Given this list of marker genes ERCC1, KIAA0319, XBP1, DDRGK1, SHARPIN, RGS8, HSPA5, TRAFD1, KLKB1, MMP14, TRIM11 (NCBI Gene Id 81559), TAF9, TKFC, MIR101-1, HFE, PDCD1, ADRB2, DGKD, TMEM64, IGBP1, EIF3A, MAGI2, TRABD2A, FBP1, TSKU, AKT1S1, HDAC7, DAB1, CLASP2, MPIG6B, SMCHD1, TRIM21, CGAS, MIR20A, PID1, FGG, INPP5A, PPP3CB, PADI2, UBASH3B, LRRC14, CDK3, IFNA2, MIR4286, MIR130A, GGNBP2, ELF1, ARR3, SYNJ2BP, ARG2, TNIP2, PTPN3, MIR130B, SQSTM1 (NCBI Gene Id 94002), EXTL3, SIRPA, CHRD, RHOH, BDKRB2, CUL3, CIT, ARHGAP12, CDK12, MIR31, RNF43, RRN3, MIR26B, FOXO1, ATAD3A, UCHL1, ATM, CCR2, SHH, CYRIB (NCBI Gene Id 51571), IRAK3, RGS13, MIR483, PLK1, ADAMTS12 (ADAM metallopeptidase with thrombospondin type 1 motif 12), CST7, RTCA, HOMER2, EID2, COMMD1, TAX1BP3, USP20, MAD2L2 (NCBI Gene Id 10459), ERCC6 (ERCC excision repair 6, chromatin remodeling factor), NCOA7 (NCBI Gene Id 135112), FEM1A, ARHGAP29, MIR9-1, PKHD1, CCDC22, TAF1, RASGRF1, PPARA, IL1RL1, IRGM, NUDT16L1, TXNDC12, YJU2, GPATCH3, BCL9L, TRAF3IP1, MIR125B1, HTRA1, EZH2, KNG1, MICOS10-NBL1, SAR1B, TBC1D7, DKK1, MCC, MIR323A, MIRLET7G, AZI2, AMBP, PIAS4, SIGIRR, NGFR, FZD9, SEC13, IGFBP6 (NCBI Gene Id 3489), BCL2L12 (NCBI Gene Id 92647), LMNA, NCOR2, GPRC5A, NPY5R, MIR99A, MIR1224, MLLT3, RTEL1, SMAD6, PRKCZ, CREBRF, TP53, HGF, PELI3, NPC1, TNFRSF14, FRMD8, ACOD1, RGS21, PYCARD, MAPK14, RGS17, ATXN1, FURIN, PIK3CB, VSIG4, SH3RF1, METRNL, FCGR2B, PAK1IP1, ADAM17, SERPINB2, RGS3, BRD4, MEAK7 (MTOR associated protein, eak-7 homolog), MIR1298, PSMA1, RASA4 (RAS p21 protein activator 4), YWHAE, FHL2, OFD1, HDAC3, CSNK1E, CASTOR1, USP18, MIR181C, MEN1, MAGEA1, ENG, ELL3, DLX2, PCGF2, MIR708, WTIP, SENP3, WNK1 (NCBI Gene Id 9872), CDK5RAP3, MIR326, KLHL31, TARBP2, NECAB2, TMEM127, ARID4A, EPHA4, PREX2, BAX, GRK3, MIR92B, CDH2, CSNK1A1L, EGR1, MTNR1B, GFRAL, TLR6, FAP, TLE2, PDGFRA, ITGAV, HLX, ADORA2A, RTN4R, GPR18 (NCBI Gene Id 2841), STAT1, CYP26B1, MIR19B1, HLA-B, MIR361, ZBTB7B, NME5, NDUFC2, ADTRP, SMURF2, ZDHHC12, CD22, RORA, APCS, IL2RA (interleukin 2 receptor subunit alpha), HHEX, SLAMF8, MIR210, BTRC, MAPKBP1, SERPINF2, MIR16-1, FGF10, SFRP2, INS, OLFM4 (NCBI Gene Id 10562), TEK, MIR520C, APCDD1L, SPRED2, MARCHF7, PMEPA1, DYRK3, PHF14, SKA3, AIF1 (allograft inflammatory factor 1), GIT1, DLG1, CRHBP, KCTD6, BCL3, NEURL1, ADM, MIR206, ANXA2, MSTN, INPP5K, APPL2, TMEM196, ELF4, FER, ALPK2, MMRN1, GPR161 (G protein-coupled receptor 161), UBXN1, PVR, LDLR, CD300LF, CLEC12B, ATF4, HYAL2, CD96, NR1H3, ATF6B, PHLDA3, FLCN, RUBCN, PRMT1, RNF34, MIR107, RASL11B, STAT5A, DKK3, MICA, HMGA2, SLC25A4, CYLD, SAP30, TAX1BP1, LONP1, MIR519A1 (microRNA 519a-1), TRIM38, RGS22, BIRC7, VPS11, CSNK2A2, APPL1, SERPING1, TRIAP1, IL1R2, GLI3, STMN1, DEFB114, GPC1, PEBP1, EYA4, PYDC5, PDE11A, BMP2, DYRK2, NXN, TNFAIP1, FBN1, BANK1, RGS18, MIR508, MIR199B, NR4A2, WNT1, NPY, DAG1, CAV3, ARRB2, NKIRAS2, FUZ, IGF1, LMBR1L, ARNT, IL33, DUSP26, PRKACA, COL3A1, SOSTDC1, MIR497, SOCS1 (NCBI Gene Id 8651), MIR149, CDK20, AMFR, NOMO1, ARRDC3, ERFE, TLE3, NLRP3, CEACAM1 (CEA cell adhesion molecule 1), TBC1D24, TBX21, MICB, CCL5, F2, MET, IFI35, OVOL2, ADIPOQ, MIR665, TPBGL, TRIM31, DGKZ, SHANK2, SESN1 (NCBI Gene Id 27244), ITGB1, DRD1, DRD3, GRID2, ERRFI1, TNFSF4, IFNL1, KIF7, DLL4, NFATC4, DSG2 (desmoglein 2), PRKCQ, TLE4, UBR1, SPN (NCBI Gene Id 6693), CD55, MIR920, MIR375, FBXW8, PGLYRP2, DLL1, HAPSTR1, NBL1, TGFB1, TAFA3, LPCAT3, C8orf44-SGK3, OAS1, CCDC125, SHLD2, AHSG, MIR106A, GPR17, MIR302E, ADAR, PSMB4, YWHAG, LYAR, HERC4, NCL, USP15 (ubiquitin specific peptidase 15), JADE1, HIC1, UACA, GIPR, BICC1, DKK4 (dickkopf WNT signaling pathway inhibitor 4), NEUROD1, TET1, ATP2B4, GLG1, MAD1L1, HMGB2, MIR503, SPRY2, INPP5F, YAP1, ICAM1, MINAR1, MIR34C, CHRDL1, ADGRA2, ERBB3, TSC1, PLXNA3, PRAME, GRM5, CD274, DLX1, KEAP1, PRKAR2B, SH2D1A, CR2, TAFA5 (NCBI Gene Id 25817), TULP3, DICER1, MAGEA3, PPIA, EGFR, OPA1, MIR29C, CR1, A2M, LTBP1, ACP5 (acid phosphatase 5, tartrate resistant), SLIT2, INPPL1, HOMER3 (homer scaffold protein 3), TRIM33, CXCL8, SPINK5, PHPT1, OPTN, CYREN, TRIM60, HIGD1A, SEC14L1, TMEM14A, TIGIT, MMP3, HIF1A, SKOR2, DRD2, MIR590, RPS3, KPTN, KBTBD6, ZNF385A, NF2, KANK1, BMP4, HLA-A, DUSP3, MIR204, GRB10, GPR108, WFIKKN2, GSTP1, MDK, SEMA6A, CBY1, FAIM2, FZD6, ABL2, DUSP8 (NCBI Gene Id 1850), STRADB, CHD8, SIGLEC10, BRCA1, CHRNA7, HLA-F, CREB3L1, FGR, SYNGAP1, NOL3, BAG5, SOCS3, NLK, BICD1, NCK2, PHB2, NFKBIL1, IL4R, NMI, KDM1A (NCBI Gene Id 23028), CSK, MAPK8IP1, SH2B3, MIR27A, HELB, MIR329-1, SLC12A2, TRIM15, USF1, SOCS5, DKKL1, DAB2IP, EYA3, PDGFB, MKRN2, CTNND1, NKD2, MIR218-1, CRTC3, MIR200B, TREM2, PROC, PIK3R2, MAP2K3, ITFG2, NPFF, DUSP22, NHERF1, OTUD5, ARRB1, BLVRB, BMP7, SMPD3, PARP14, ADRA2A, G3BP1, C5, DNAJB9, APOA1, DUSP1, MIR424, HEYL, ANXA4, PDE4D, HSPA1B, SIRT7, DYRK1A, SERPINB4, GNAI2, DLL3, LGALS1 (NCBI Gene Id 3956), UBR5 (ubiquitin protein ligase E3 component n-recognin 5), ABCA7, TGFBR1, MIR6869, SPRY4, HLA-E, AKT2, HMOX1, FIGNL1, USP5, CRKL, FRZB, EPN2, ZFYVE28, FIGNL2, IL2, CAVIN3, SPRED3, FAM89B, WNT5A, SESN3, PPP6C, HIPK2, HTRA2, ITPRIPL1, NDUFAF2, SAP130, HDAC2, RASAL3, CASTOR3P, RAF1, PPP1R15B, PPP1R13L, RRM2B, ATXN3L, CSNK2A1, NOP53, TMSB4X (NCBI Gene Id 7114), TCIM, HELLS, TWIST1, INTS9, NPLOC4, ZNF675, SLC39A8, FBH1, TMBIM1, MIR195, DUSP10, NFE2L2, KIR2DL4, SMCR8, PAFAH1B1, AKT1, NPPA, INPP5D, DCN, UBQLN2, SHISA6, ITGA6, PRKCD, SLAMF1, EGLN1, CILP, PTPN22, LEP, MORN3, MIR132, DACT2, IER3, DPP4, SIX3, CNKSR3, CSNK1A1, MIOS, BCR, ALOX5, KREMEN1, TSPAN15, TERT, MIR874, NLRP2, FBXL2, F12, DLK1, HIPK3, MEFV, PLK3, SOD1, IL17RD (interleukin 17 receptor D), MAP3K20 (NCBI Gene Id 51784), FANCB, PLCL2, SLC35C1, SPRY3, CD74, MIR212, TTLL12, LAMP2, ENO1, APC, DAB2, NRG1, PF4, ONECUT1, SMURF1, TBK1, ECM1, RCAN1, SKOR1, PPIF, PTGIR, PYDC1, BID, EMILIN1, ACKR3 (NCBI Gene Id 57007), SOCS7, DKK2, ANKRD6, BRMS1, GIGYF2, PIM1, GLI1 (GLI family zinc finger 1), WNT4, IL12B, STK38, RGS7BP, RGS5, TLE7, MIR4691, PIK3IP1, RGS11, TREX1, FNIP1, HHIP, MTOR, STAMBP, IL6ST, BEND6, PTPN18, PER1, PRR5L, ARHGAP22, MIR365A, STRAP, OGG1, CARTPT, OTUB1, DUSP5, ZC3H12A, PDE8B, SYVN1, IL20RB, NCLN, FGF9, GDF15 (NCBI Gene Id 9518), SGTA, CD44, MNT, CARD8, RGS2, UFD1, NAIP, RNF26, RB1 (NCBI Gene Id 92728), SMAD3, SHLD3, MVK, INSIG2, DHX58, PRKAA1, FKBP1B, CLU, RIPK1, URI1, AQP11, SFN, EYA1, PRELID1, TRAP1, SMARCA4, MIR34A, PTPRD (protein tyrosine phosphatase receptor type D), ARID4B, MAPKAP1, TSC2, RGS19, STRN3, GATA4, ASXL1, RADX, FRMD8P1, SPSB3, INVS, SIKE1, IFI6, TCF21, PARPBP, ALOX12, RC3H2, CNOT9, EPPK1, SIRT2, ZNRF4, MRE11 (NCBI Gene Id 4361), DUSP7, MIR564, WWOX, FKTN, VWC2, RGS9, GBP1, SOX17, AR, SCAI, TMBIM6, TRIM65, ARMC10 (NCBI Gene Id 83787), WNT3, LACRT, DLK2, HTRA3, EDN1, TMEM161A, UFL1, SCRT2, OTUD3, SAA1, ACAA2, NCK1, CTDSPL2, ARG1, MIR141, MMRN2, LPAR1, USP49, MIR186, RUVBL2, PARL, CD80, NKX3-1, F11, SNAI2, KLF7, ACVR1, PTPN2, SMAD7, MAPK7, SHISA3, RIF1, RHBDF2, PHACTR4, LAX1, C1QBP, CALR, LTF, PRKAR2A (NCBI Gene Id 5576), DDX39A, GRB14, RASSF2, PALM3, ENPP3, OGT, NOTUM, PBK, PIN1, GNAS, PLAU, IFNB1, SNX25, BANF1, RNF149, RGS14, SNCA, RPS6KA6, FFAR4, CIDEA, PLEKHA1, HECW1, PHLDB2, BACE1, SPRY1, KRT1, TRIM45 (NCBI Gene Id 80263), CRYBA1, CYP26A1, AXIN1, FCRL3, SLC35F6, CD300A, CUL7, BRMS1L, PELI1, SUFU, MIR1-1, IL4I1, PVRIG, MIR214, IL19, ERBIN, TPBG, APOE, DUSP19, WDR24, SOCS2, PTPRE, LEPROTL1, NECTIN4, GRINA, SNAI1, CEP63 (centrosomal protein 63), NRROS, SLC25A6, CX3CL1, TRIM40, UBE2D3, BAMBI, FGF2, TMEM88, ABL1, MIR340, ADORA1, MIR766, UBE2D1, PTPRS, SERPINE2, UCN, FBN2, UBXN2A, PYCR1, HTRA4, LOX, PRDX2, VRK3, TNS2, RPGRIP1L, IL10RA, F2RL1, TRAIP, PDX1, MTMR4, ITCH, PSME3, DACT3, IL1A, LRP4, CLOCK, STYXL2, SH3BP1, MIR222, PSMD10, NCKAP1L, NT5C2, STRIP1, ADAMTS18 (ADAM metallopeptidase with thrombospondin type 1 motif 18), RECQL5, ENPP1, PLK2, IL4, MIR873, RPS6KA1, MIRLET7E, ACE2, MIR451A, PTGS2, RACK1, WDR91, CD72, NR1D2, APLNR, TRIB1, APLP1, KAT5, PPP2CB, SKIL, NLRX1, MIF, CD3E, PPP3CA, BARX1, RASA2, IL22, FST, MYOZ2, LILRA2, ITGA3, ISG15, SIN3A, GRN, SULF1, PPP2CA, PIP4K2C, IL7, MIR449A, KLHL15, PLEK, CD109, TCF7L2, ISL1, TLE6, STMN3, TNFRSF11B, THBD, CHST11 (NCBI Gene Id 55807), NR0B1, MIR27B, TWSG1, USP14, LIF, IGFBP1, HTT, TRIM32, SHLD1, P2RX7, CCL2, TGIF1, NANOS3, NOTCH1, ITGA1, INPP5E, ANGPT1, ING1, LATS2, UBR2, ROBO2, NKIRAS1, AARS2, TYRO3, IGSF1, CRY1, GPR37L1, DGKG, SIVA1, NEO1, SGK3, ARHGAP42 (NCBI Gene Id 83935), MIR93, CLEC12A (C-type lectin domain family 12 member A), PARP1 (poly(ADP-ribose) polymerase 1), FXN, THEM4, KANK2, RGMA (NCBI Gene Id 56963), FOXH1, SKI (SKI proto-oncogene), NLRC3, MAPK3, MARK3, MMP26, PCBP2, GATA3, MIR573, TNFAIP8L2, LYPLAL1, TBC1D10C, CLDN18, BMI1, HMGXB4, RHOA, KBTBD7, RFFL (NCBI Gene Id 117584), MRAP2, PROS1 (NCBI Gene Id 5627), ADGRG3, SH3RF2, ARHGAP35, OTUD4, ARHGAP44, LGMN, PDE10A, HIF1AN, MIR133B, MGRN1, MIR490, PEG10, FOXF1 (NCBI Gene Id 2294), MIR376C, BFAR, SFRP5, KLRK1, RGS12, ZDHHC18, ILRUN, ZMYND11, ALOX15, TMPRSS6, PHIP, PDCD4, EIF4E2, CXCL13, NCOA2, SFRP1, ZNF536, PRKAR1B, USP10, DDIT4, GRAMD4, ARHGAP17, TICAM2, PSCA, FXR1, MDM2, CYP7B1, SLC2A10, CBL, GPRASP1, TMC8, EZR, PHLPP1, MMP12, WFIKKN1, RASA4B, OTOP1, PTPRU, IL13, TMEM170B, SZT2, TAOK3, IFT80, CHRDL2, GPR155 (NCBI Gene Id 151556), FAIM, EPHA7, CD59, TMX1, PARP3, RASIP1, PIAS2, MIR302C, MDFI, LGR4, SIAH2, MIR15B, GRK2, HJV, MIR185, GBP7, ACP4, MIRLET7A1, MIR103A1, METTL3, USP38 (ubiquitin specific peptidase 38), PGLYRP1, CYP26C1, NFKBIA, TRIM39, MIR98, ARHGAP30, PTPRJ, ASAH2, MIR105-1, RITA1, SOD2, FOXO3, REG3A, RTN4RL1, SUDS3, IGFBP3, GRB7, DUSP9, HDAC6, ENTREP1, RTKN2, OTULIN, MARVELD3, DAND5, ENDOG, CAV2, IL1B, MIR372, CACTIN, DTX4, DDAH1, PRKN, CLASP1, OTUD7B, MIR18A, ENY2, GSC, SLMAP, UBE2N (ubiquitin conjugating enzyme E2 N), TNIP1, LRRK2, LEPROT, IL22RA2, VTN, DUSP13B, PRDM16, SOST, PLIN5, NPY2R, TLE1, MIRLET7B, JAK3, NRP1, KCTD11, PEA15, GCLC, TAF3, PPT1, MAP2K1, MACROH2A1, LYN, NR1H2, RC3H1, TGFB2, FOXJ1, GSK3A, SAR1A, SLIT1, NKD1, PDE3B, IL27RA, BCL2, PPP1R15A, MUC1 (NCBI Gene Id 4582), OAS3, RPS6KB2, FPR2, MIRLET7F1, DHRS3, LPXN, RGS10 (regulator of G protein signaling 10), CD200, RBMS3, APELA (apelin receptor early endogenous ligand), ABHD8, APCDD1, SERPINB3, CDH5, SAMTOR, SH3GL2, SNX6, LEMD2, ZNF653, EPHB2, SAMHD1, NR2F2, DDIT4L, BMPER, AJUBA, PDE2A, DACT1, PLCG1, VEPH1, RIPOR2, SIRT3, CASK, ESR1, SLC6A3, MIR29A, CHMP6, FBXO7, RNF39, PRICKLE1, NPHP4, LRPAP1, WWC2, FZD1, LAPTM5, KLRD1, UCP2, IVNS1ABP, SESN2, SDHAF2, IL36RN, ITPRIP, THY1, PRNP, DNAJA1, DVL1, MAD2L1BP, DCST1, PDPK1, CITED1, IGFBP5, THBS1, GHSR, SMAD4, SARM1, MIR29B1, NLRC5, MIR181A2, SYT11, ATF3, GMIP, WNT11, NODAL, IFT172, FERMT1, LILRB1, SNX13, USP7, AKT3, BBS2, CBLB, LEMD3, UBASH3A, RASA3, CCDC3, PRDM15, UBQLN4, ARHGAP24 (NCBI Gene Id 83478), CLEC4G, HGS, AATF, UCMA, TPT1, CFLAR, LRFN5, SLC27A4, LIMD1, STAT6, CTHRC1, PTGIS, SLC8A3, RNF126, IL6, GPR31, RANBP9, VPS25, KLF4, ING2, MIR181B1, CPNE1, SMPD1, ACTN3, ATG12, XIAP, PTPRR, PDE3A, MIR23A, TAF9B, NT5E, BDNF, GCLM, HDAC1, IRS1, PTCH1, ABHD17A, NOMO3, GPX1, DUSP2 (dual specificity phosphatase 2), PRKCB, ADIPOR1 (adiponectin receptor 1), FOXP3, MMP28, GPC3, SOX9, RIPOR1 (NCBI Gene Id 79567), IL7R, WDR59 (WD repeat domain 59), IL17A, MIR129-1, MECOM, EFNA1, TNFAIP8L1, ZNF366, RNF213, PRAP1, HEY1, FAF1, CD2AP, DLC1, AGT (NCBI Gene Id 183), DDX3X, CRK, DNAJA3 (NCBI Gene Id 94389), MYOCD, NLRP6, IGF1R, APP, PAWR, LOXL3, ARHGAP25, BIRC6, ELANE, MIR19A (microRNA 19a), UBE2W, ITPR1 (NCBI Gene Id 619543), CNTNAP2, XRCC1, ZNF451, PAK5, LITAF, IKBKG, ZNRF3, YWHAB, PINK1, IL12A, SMPDL3B, BCL2L1, TMEM131L, STAP1, PDE4B, ASCL2, NLRP2B, NPRL3, PFDN5, SLA2, MIR15A, SINHCAF, DSG3, MLXIPL, KCTD10, HSPA8, BOK, ANGPT2, EYA2, SLC8A1, PRKAA2, CREB3, SHISA2 (NCBI Gene Id 404758), MIR200C, MAZ, LILRA4, APC2, INSIG1, GHITM, CAV1, ATAD5, CASTOR2, RELA, MUL1, RNF113A, SELENOS, BBS4, VCP, ITGB1BP1, RNF167, TMEM88B, IRAK2, GATA2, TMEM53, MIR135A1, BRAP, SMPDL3A, SAMSN1, WWC3, DLG5, IFT122, TRIM67, SPI1 (NCBI Gene Id 6688), MYC, PLD2, HLA-G, TLE5, CCN3, SKA1, DUSP16, MIR140, TNFAIP3, RB1CC1, LRP1, MIR373, SOX10, NFKB1, WDR41, CRIM1, PPARG, RNF125, MIR24-1, SLC24A4, STUB1, FAM3A, MPV17L, DDIT3, MIR495, TSPAN8, CDKN2D, ZBTB7A, GBA1, TOB1, AXIN2, HSPB1, UBQLN1, EPO, LZTS2, WWP2, CBFA2T2, MIR203A, PLA2G10, SERPINB9, LILRB4, IGFBP2, TLR9, SOCS4, MIR1271, KLK14, PLG, RPS6KB1, CTH, MIR488, NR1H4, DRAXIN, TP53BP1, MOCS2, NDFIP1, NKX2-1, PDGFA, RBBP7, SEMA5A, CCDC88C, IL10, CSF2, WFDC1, SOCS6, SRC, PLAT, GPS2, NOS3, TBX18 (NCBI Gene Id 9096), MIR146A, GRIN3A, PBLD, HSF1, NOC2L, MIR498, WIF1, KIF26A, FYN, CTNNA1, CTNNBIP1, ATXN3, RASAL1, LFNG, AMER1, PTPN6, C12orf43, MIR302B, CR1L, MOSMO, LRRC32, MIR152, MAGEF1, ADAMTSL2, PALM, CPB2, FBLN1, FAM76B, PLAUR, CNOT1, BCL6, MVP, CHAC1, MIR187, EMD, CNOT2, DUSP4, RPS19, NPRL2, LGALS9, PPARD, RAB7B, CD46, BECN2, VPS35, NENF, SERPINE1, WNT16, RIN3, NR5A2 (nuclear receptor subfamily 5 group A member 2), RGS20, MIR199A1, RIOK3, GGT7, PKIA, POLQ, TRIM72, CBLC (NCBI Gene Id 23624), PRKG1, CD9, SEMA3F, NRARP (NOTCH regulated ankyrin repeat protein), MOB4, MAPKAPK5, CHRNA9, BMP5, QARS1, MESP1, CALCA, CTNNB1, VGLL4, NPHP3, KLRC4-KLRK1, FGA, SEH1L, APLN, JAGN1, SOX30, NF1, MIR885, CXCL17, RBX1, CARD16, PRKAR1A, MIR205, PPEF2, CCAR2, NOG, UBE3A, CERS2, MRAP, TNIP3, LMO3, HERPUD1, WWC1, MIR92A1, HRG, MAP2K5, SPART, PAQR3, PRKACB, CCNC, VASN, C1QTNF3, SPINK1, CX3CR1, SBNO1, HEY2, CYP19A1, NHERF4, TSG101, IFI16, SUSD4, PRDM14, TRIB3, CRY2, PIP4K2A, CORO1B, STK3, SPP1, FBXW7, MFN2, C5AR2, STAT3, PREX1, NLRP4, OXR1, DEFB118, CXCL12, AOAH, RNF115, PGLYRP3, PDCD6, KCTD13, IL22RA1, PTPRO, AARS1, PPP2R1A, PPP5C, BTN2A2, ULK3, AIDA, MIR142, MEGF8 (multiple EGF like domains 8), SRMS, ATG5, YES1, AURKB (aurora kinase B), FSTL4, RAB7A, GATA1, FKBP1C, CADM4, KICS2, TNFAIP6, VPS18, LZTR1, PTGER4, RFX4, NR1D1, MBIP, MIR25, DDIAS, TRIM27, SIRT1, FGL2, GDNF, DUSP6 (dual specificity phosphatase 6), RYK, USP47, GRB2, TFPI, C3orf33, CHEK2, MCTP1, FOXM1, TANK, RPH3AL, YWHAZ, TNR, ZNF592 (zinc finger protein 592), NECTIN2, C9orf72, WNK2, GTF2H2, MIR30C2, RMI2 (RecQ mediated genome instability 2), SLIT3, H2BC11 (NCBI Gene Id 8970), CIB1, AHR, MYOC, MCL1, CDH3, HCK, NEDD4, MIR138-1, ADCYAP1R1, MIR125A, COL2A1, HAVCR2, CASP8, SMIM30, SOX2 (NCBI Gene Id 6657), C4BPB, CNOT7, PIM3, PIBF1, BPIFB1, HSPA1A, PARK7, ARHGAP45, MIR133A1, MIR223, MIR34B, CXXC4, CISH, APOH, TFIP11 (tuftelin interacting protein 11), RGS4, IRF4, NDRG4, PPP2R3A, C4BPA, XCL1, NCOA5 (NCBI Gene Id 57727), MLIP, GLIS2, TSPAN6, PTPRC, NONO, MIRLET7C, ANXA1, STRN4, TNF (NCBI Gene Id 7124), ADA, MACIR, TP63, RNF169, SULF2, GSK3B, SOX13, SPX, AGTR2, C1QTNF12, TMED2, USP25, AMER2, TRABD2B (TraB domain containing 2B), C1QTNF1, FGB, PTPRT, LATS1, NKX2-5, TNFRSF1B, MMP9, ROBO1, RGS9BP, RGS16, PYDC2, PPM1A, RABGEF1, TRIM59, PIP4K2B (NCBI Gene Id 8396), MASP1, MAPK8IP2 (NCBI Gene Id 51748), MIR17, CPTP, GP1BA, YTHDF2, PXDN, MYOZ1, IRAK1, LBH, TERF2, KMT5A, FOXP1, ASPN, TLR4, ASH1L, WWTR1, CD200R1, HERC2, MFHAS1, STK4, SORL1, PTTG1IP, ADRB3, ARRDC1 (NCBI Gene Id 92714), BTNL2, STK11, WNT5B, CGNL1, EPM2A, SH3BP4, SAG, GREM2, MIR342, AIM2, RGS6, SCYL2, MTM1, SPAAR, PP2D1, BAK1, FCRLB, MIR26A1, RGS7, ARHGEF2, TNFRSF1A, HACD3, APOD, SLC25A5, WFS1, CD160, SMAD5 (NCBI Gene Id 4090), RBPMS2, ERCC4, SAP30L (NCBI Gene Id 79685), MARCHF5, SYK, ONECUT2, FNDC4, YBX3 (NCBI Gene Id 8531), CTTN, GREM1, PSEN1, SVIP, CHP1, IGFBP4, C1QL4, GPER1, HEG1, STAT2, RGS1, UNC5B, GHRL, KLRC1, GPR21, YTHDF3, WNT3A, CD69, GAS6, PHB1 (NCBI Gene Id 5245), RNF152, DEPDC5, DUSP29, CER1, BMAL1, GDF3, MIR100, VHL, TGFBR3, HYOU1, SFRP4, RUNX2, PTCH2, KCTD21, PPP1R10, SLC25A31, IL1RN, HUWE1, NDRG2, SNX5, PTPN12, CTNNA2, SNIP1, TNFSF18, NCOR1, MKKS, TBX20, LRIG2, VWC2L, LRP2, MIR221, NUP62, SPRED1, LGALS3 (NCBI Gene Id 81625), MIR3909, SCG2, MIR21 (microRNA 21), PPM1B, DDT (NCBI Gene Id 91323), PRKDC, MIR519D, CARD19, LDLRAD4, PTEN, FKBP1A, FSTL3, RBBP4, AUNIP, AJAP1, PIP5KL1, ZGPAT (NCBI Gene Id 84619, zinc finger CCCH-type and G-patch domain containing), HLA-DRB1, PTPN1, UBAC2, NLRP12, EGFL7, MIR145, CHRNA10, DEPTOR, here is a description of the gene set: Any process that stops, prevents, or reduces the frequency, rate or extent of a response to a stimulus. Response to stimulus is a change in state or activity of a cell or an organism (in terms of movement, secretion, enzyme production, gene expression, etc.) as a result of a stimulus. Human Gene Set: GOBP_NEGATIVE_REGULATION_OF_RESPONSE_TO_STIMULUS studied in species Homo sapiens